Given this list of marker genes OSTC, TMEM258, ZDHHC3, GALNT1, GSK3A, CSNK1A1, ZDHHC11, SUMO1 (small ubiquitin like modifier 1), RPN1 (ribophorin I), MAGT1, ANO1, UBC, SRPK1, ANO10, ST3GAL3, EDEM2, DDOST, TMPRSS2, ACE2, ANO4, ANO2, ANO6, OST4, SRPK2, MOGS, CANX, STT3A (NCBI Gene Id 8071), ST6GAL1, PRMT1, MAN1B1 (mannosidase alpha class 1B member 1), ST3GAL2, DAD1 (defender against cell death 1), ANO7, MGAT1 (NCBI Gene Id 4245, alpha-1,3-mannosyl-glycoprotein 2-beta-N-acetylglucosaminyltransferase), TUSC3, RPS27A, STT3B, MGAT2, PRKCSH, ST3GAL4, PARP10, MGAT4B, PARP14, ZDHHC5, ZDHHC20, GSK3B, ZDHHC9, ANO8, PARP9, ST6GALNAC3, MGAT4A, ST6GALNAC2, ANO3, GANAB, ST3GAL1, ZDHHC8, ANO9, PARP6 (NCBI Gene Id 56966), GOLGA7, MAN2A1, PARP16, FUT8, ZDHHC2, PARP8, FURIN, MGAT5, RPN2, UBA52, MGAT4C, ST6GALNAC4 (NCBI Gene Id 27090, ST6 N-acetylgalactosaminide alpha-2,6-sialyltransferase 4), PARP4, UBE2I, ANO5, UBB, here is a description of the gene set: Late SARS-CoV-2 Infection Events Human Gene Set: REACTOME_LATE_SARS_COV_2_INFECTION_EVENTS species: Homo sapiens